The following is a description of a gene set: Human Gene Set: GOBP_POSITIVE_REGULATION_OF_MITOCHONDRIAL_DEPOLARIZATION Any process that activates, maintains or increases the frequency, rate or extent of the change in the membrane potential of the mitochondria from negative to positive. species: Homo sapiens, and this is the list of marker genes: DCN, MLLT11, P2RX7, TSPO, RACK1, PARP1, ADCY10, KDR, MYOC